Given this list of marker genes LINC02003, PICSAR, DAOA-AS1, OTOP2, STRN, GCOM1, C10orf95-AS1, ADAMTS5, USP30-AS1, DPY19L4, GLS, BTF3P12, DEFA4, MDS2, SPATA25, ZNF484, COA5, PURB (NCBI Gene Id 5814), RAB30, SMDT1 (single-pass membrane protein with aspartate rich tail 1), ZFP1, SNHG3, ZNF138, NDUFS1, CCDC65, RAD9B, TAF13, DNAJA2, GXYLT2, FAM241A, SERPINA3, CYP51A1-AS1, NIPSNAP2, LINC00477, FHDC1, PLPBP (NCBI Gene Id 11212), XBP1, GRAMD2A, MFSD14A, MAMDC2-AS1, OAF, IQCM, AHCY, HYCC2 (NCBI Gene Id 285172), RETREG1, AKT3, AKAP12, CFAP74, ASB14, TBC1D12, TRABD2A, THAP5, TPT1P8 (TPT1 pseudogene 8), SSTR5, IL6ST-DT, BNC2, CRX, HMGN5, PSMA8, PJA2, FGF23, CILP, GSTCD, ACTN1, ZNF407, C1orf50, BLID, RIN2, SMARCA5, MINDY4, CHMP1B, LEMD3, CFAP47, SNTB1, MMP3, GRM7, RCN2, CECR2, MCOLN3, RPAP3, OXNAD1, LINC00163, SESN3, MARCHF7, GANAB, KRT19P2, DOK5, TXK, ZNF43, TRIM2, HSF2, TTTY2, ITGA6, CAPNS2, MAPDA, ARMCX1 (armadillo repeat containing X-linked 1), SPATA6 (NCBI Gene Id 54558), RDUR, RHBDD3, USP10 (NCBI Gene Id 9100), DMXL1, EPPK1, BEX3, SLC15A2, STRA6, FAM95A, AFP, TEX41, UNKL, SLC8B1, PRR9, N4BP2L1 (NEDD4 binding protein 2 like 1), GAS2L2, MRPL50, GPR160, NIF3L1, DLEU7, PLXNA4, NKAIN4, CNKSR1, FAHD2A, GRAP2, STIL, FAM193B, ZNF83, P4HA3, ZNF702P, CLHC1, SPTBN4, ZNF33A, SSPN, TENT2, STAT1, CFAP99, POM121L8P, PPCS, RPRD1A, FAM78B, TCEA3, ZNF813, RABEP1, ANXA9, ZMYM2, TAS2R14 (NCBI Gene Id 50840), LYRM9, SLC39A10, FGF8, SPINK7, MTARC2, LRP2BP, GARIN6, SPDYE1 (speedy/RINGO cell cycle regulator family member E1), C8orf33, PDSS2, TLK1, SCML1 (Scm polycomb group protein like 1), CATSPER3, IL36G, THOC7, ASB8, RGL4, SLC4A3, SFMBT2, TRAPPC13, ZNF844, CHST5, NSMCE1, ZNF638, TNFRSF10D, STYX, BAG4, CALCB, FBXO28, NLE1, BBS2, RNF103, ENOX1, GPRASP2, AIF1, H1-0, LINC02891, MORC3, TNFRSF8, TAFA1, PGBD1, GPR15, ARB2A (NCBI Gene Id 83989), DRAM2, ZNF439, ATP11B, BNIPL, here is a description of the gene set: Human Gene Set: GSE26928_EFF_MEM_VS_CENTR_MEM_CD4_TCELL_DN Genes down-regulated in comparison of CD4 effector memory T cells versus CD4 central memory T cells. from publication Chevalier N, Jarrossay D, Ho E, Avery DT, Ma CS, Yu D, Sallusto F, Tangye SG, Mackay CR (PMID 21471443) species: Homo sapiens